The following is a description of a gene set: Human Gene Set: OCT1_04 species: Homo sapiens Genes having at least one occurrence of the motif NNNNNNNWATGCAAATNNNWNNA in the regions spanning 4 kb centered on their transcription starting sites. This matches the POU2F1 transcription factor binding site V$OCT1_04 (v7.4 TRANSFAC)., and this is the list of marker genes: UNC13B, PHKA1, ZNF362 (NCBI Gene Id 170467), EHF, HOXC10 (homeobox C10), GABRG1, SH3BGRL, HOXD4, IRX4, IL17F, OLIG3, SLC38A4, PAX6, MOXD1, PRDM2, NR3C2, RAB6C (NCBI Gene Id 84084), OMD, LMO4, HOXD10, YTHDC2, TSPYL2, SALL3, MYO18A (myosin XVIIIA), GALNT1 (polypeptide N-acetylgalactosaminyltransferase 1), SMARCA2, CLCA3P, CUX1, TMSB4XP1, FGF13, ATP1B2, OPCML, GRIN3A, FOXP1, TBXAS1, LDB2, LRMDA, MNT, ANK3, TMSB4XP6, DTNA, PURA, PITX2, ARHGAP30, KCNJ13, DLX1, AHCY, KCNQ1DN, POU2F1, PTPRD, ZIC4, SP6, RUNX1, NFIA, C8orf34, CDX4, ISL1, ZBTB20, CCDC91, NCAM1, CNOT2, CNMD, THAP2, AGBL4, TMSB4XP4, SCUBE2, TWIST1, CSF3, NIN, LMO3, CASK, HOXB3, SHOX2, THRA, FOXP2, LMNA, C12orf57 (NCBI Gene Id 113246), PLAGL1, HNF1B, ZNF407, POU3F4, IL25 (interleukin 25), BNC2 (NCBI Gene Id 54796), ZC3H14, NSF, OLFML3, ARMH4, SEL1L3, SLITRK2, ARF6, CACNA1D, CCND1, BCL11B, MID1, HDAC9, UBE2E4P, LUC7L3, ZIC3, LCOR, PPP3CB, ANKRD39, FOXG1, PAX2, DLG2, NEUROG1, SLC7A11 (NCBI Gene Id 23657), ZFPM2, C2CD5, FBXL19-AS1, ETV1, SLC17A6, CADM1, NOTCH2NLA, ARPC5, EYA1, MAB21L2, H3-3B, IRAK1, TMTC2, GRIK3, PPIP5K2, EIF4A1, NSMCE3, NFIX, NCOA5, SCML4, SLC26A7, PATZ1, TPD52, SERTAD4, CADM2, HOXC4, HOXC5, KRT8P41, CDH13, CPEB4, PNMA1, COLCA1, TAL2, MBNL1, STOML2, TTI2, SCEL, KCNQ5, EPCIP, ARMCX4, GPM6A, SKIDA1, TP53INP2, C8orf82, ENSG00000291228, UQCC2, SLC35C2, XYLT2, GRM8, ATOH1, BARHL2, OR10J1, PTEN, CHD2, FNBP1, PRRC2A, GNAO1 (NCBI Gene Id 2775), UCKL1, HOXC6, VGLL3, PI4KB, PHOX2B, HS3ST1, PKP4, NR6A1, NOTCH2, FES, MPPED2, DIXDC1, PDE1A, LINC01597, GABRG2, GPR85, ZIC1, NDP, ELAVL4, STX12 (NCBI Gene Id 23673), PPP2R3A, RGL1, HOXA3, CDC42EP3, NCALD, TCEAL1, TMSB4XP8, CNTN6, SYT6, MEIS1, CD86, SCP2D1, ACBD4, ITM2B, LAMTOR5, POU3F2, PDZRN4, DMD, CNTF, CACNA1C, KCNS3, PRKCB, RHOBTB2, ZBTB10, PROKR2, GAB2, NDUFA4, PBX1, BCL6, BCL2L1, CHM, GDI1, PMCH, MITF, COMMD10, CHD6, ST13P4 (ST13, Hsp70 interacting protein pseudogene 4, NCBI Gene Id 88248), TSPAN13, MEF2C, FEZF2, ZFC3H1, SYNPR, JAM3, HFM1, ANKRD17 (NCBI Gene Id 84177), FAM50A, TAS2R13, SRSF7, NPHP4, ACKR4, TDRD5, OR10A5, EPHB3, RELCH, TOPBP1, TBR1, MAP2K6, HOXA10, JAZF1, NPTX2, SOX5